The following is a description of a gene set: studied in species Mus musculus The chemical reactions and pathways involving polyamines, any organic compound containing two or more amino groups. Mouse Gene Set: GOBP_POLYAMINE_METABOLIC_PROCESS, and this is the list of marker genes: Oaz3, Azin1, Aoc1l3, Dhps, Odc1, Amd1, Amd2, Azin2, Smox, Sat2, Srm (NCBI Gene Id 99964), Agmat, Hdac6, Oaz1, Satl1, Aoc1, Hdac10, Oaz2, Sat1, Ldc1, Aoc1l2, Aoc1l1, Sms, Paox